Given this list of marker genes Cited1, Senp2, Plac1 (NCBI Gene Id 56096), Tex19.1 (testis expressed gene 19.1), Xist, Nrk, Zfp36l1, Ascl2, Zfat, Birc6, Akt1, Hectd1, Phlda2, Fbxw8, Lif, Gjb5, Igf2, Adm, here is a description of the gene set: studied in species Mus musculus Mouse Gene Set: GOBP_SPONGIOTROPHOBLAST_LAYER_DEVELOPMENT The process in which the spongiotrophoblast layer of the placenta progresses from its formation to its mature state.